The following is a description of a gene set: Genes higher expressed in the worst 25 mesothelioma survivors compared to the 25 best ones. from publication López-Ríos F, Chuai S, Flores R, Shimizu S, Ohno T, Wakahara K, Illei PB, Hussain S, Krug L, Zakowski MF, Rusch V, Olshen AB, Ladanyi M (PMID 16540645) Most gene expression profiling studies of mesothelioma have been based on relatively small sample numbers, limiting their statistical power. We did Affymetrix U133A microarray analysis on 99 pleural mesotheliomas, in which multivariate analysis showed advanced-stage, sarcomatous histology and P16/CDKN2A homozygous deletion to be significant independent adverse prognostic factors. Comparison of the expression profiles of epithelioid versus sarcomatous mesotheliomas identified many genes significantly overexpressed among the former, including previously unrecognized ones, such as uroplakins and kallikrein 11, both confirmed by immunohistochemistry. Examination of the gene expression correlates of survival showed that more aggressive mesotheliomas expressed higher levels of Aurora kinases A and B and functionally related genes involved in mitosis and cell cycle control. Independent confirmation of the negative effect of Aurora kinase B was obtained by immunohistochemistry in a separate patient cohort. A role for Aurora kinases in the aggressive behavior of mesotheliomas is of potential clinical interest because of the recent development of small-molecule inhibitors. We then used our data to develop microarray-based predictors of 1 year survival; these achieved a maximal accuracy of 68% in cross-validation. However, this was inferior to prognostic prediction based on standard clinicopathologic variables and P16/CDNK2A status (accuracy, 73%), and adding the microarray model to the latter did not improve overall accuracy. Finally, we evaluated three recently published microarray-based outcome prediction models, but their accuracies ranged from 63% to 67%, consistently lower than reported. Gene expression profiling of mesotheliomas is an important discovery tool, but its power in clinical prognostication has been overestimated. studied in species Homo sapiens Human Gene Set: LOPEZ_MESOTHELIOMA_SURVIVAL_WORST_VS_BEST_UP, and this is the list of marker genes: DLGAP4, CDC25C, TGFB1I1, PLXNA3, CCND1, VSIG10, DDAH1, MRGBP, ACOT7, FLNB, LOX, PSRC1, JPT1, CDC42EP3